Given this list of marker genes NGF, ARPC3, CALR, MAPK10, DUSP3, FASLG, ITPR2, RAF1, ACTR3, LCK, EGFR, NOD1, PLCG1, MKNK1, HSP90B1, IRAK4, PAK4, TSC2 (NCBI Gene Id 7249), NFKBIB, IL4, PDK1, PTEN, AP2M1, PTPN11, CAMK4, PRKAG1, TNFRSF1A, FGF6, MAP2K6, PIN1, AKT1S1, ACACA, MAPK1, UBE2D3, FGF22, TBK1, THEM4, GSK3B, MAPK9, PITX2, CDK1, NCK1, CAB39L, DDIT3, SQSTM1, RPTOR, HRAS, SFN, CAB39, ARF1, ECSIT, RIPK1, PPP1CA, TRAF2, PIKFYVE, CLTC, CDKN1A, CXCR4, RPS6KA1, IL2RG, ADCY2, STAT2, CDKN1B, GRB2, VAV3, DAPP1, ARHGDIA, YWHAB, ACTR2, PRKCB, PLCB1, MAP2K3, RPS6KA3, PPP2R1B, TRIB3 (NCBI Gene Id 57761), MAPKAP1, ATF1, PRKAR2A, FGF17, MKNK2, CDK2, RAC1, CDK4, PRKAA2, GNA14, PFN1, CFL1 (NCBI Gene Id 1072), RIT1, SLA, MAP3K7, GRK2, MAPK8 (NCBI Gene Id 5599), RALB, PIK3R3, UBE2N, SMAD2, PLA2G12A, AKT1, SLC2A1, MYD88, EIF4E, GNGT1, E2F1, CSNK2B, TIAM1, here is a description of the gene set: species: Homo sapiens Genes up-regulated by activation of the PI3K/AKT/mTOR pathway. from publication Liberzon A, Birger C, Thorvaldsdóttir H, Ghandi M, Mesirov JP, Tamayo P (PMID 26771021) Human Gene Set: HALLMARK_PI3K_AKT_MTOR_SIGNALING